The following is a description of a gene set: A molecular function regulator that activates or increases the activity of its target via non-covalent binding that does not result in covalent modification to the target. studied in species Mus musculus Mouse Gene Set: GOMF_MOLECULAR_FUNCTION_ACTIVATOR_ACTIVITY, and this is the list of marker genes: Dnaja1, Jag2, Bmp15, Pde8a, Agt, Gdi2, Wnt10a, Ramacl, Cxcl13, Atp6ap1l, Nppb, Lta, Il27 (interleukin 27), Eda, Acsl1, Tnf, Retn, Psmd14, Krtcap2, Adrm1b, Casp8, Arhgap9, Fnip1, Rheb, Adipoq, Rasa2, Mob1b, Apoa1, Mill2, Ccl17, Guca1b, Ccl21f, Nrg3, Tafa1, Arhgap28, Chn2, Tank, Ins1, Esp3, Rgs4, Il2, Ranbp1, Wnt16, Sema3c, Igfbp2, Pcna (NCBI Gene Id 18538), Elmod3, Il17c, Ghrh, Ereg, Sema4g, Stc2, Flrt3, Plcb3, Plaa, Esp4, Ifna1, Ctsg, Ralgapa1, Psenen, Map3k9, Il1f10, Tbc1d10a, Gpihbp1, Fbn1, Lrrc32, Gdf1, Alkbh1, Prkag2, Tab1, Tor1aip1, Tbc1d30, Pdyn (NCBI Gene Id 18610), Bmp4, Flcn, Gdnf, Fshb, Als2cl, Sema3f, Adap1, Retnla, Mark2, Adcyap1, Csf1, Tbc1d22b, Arap2, Ctsc, Spp1, Noxo1, Tnfsf13b, Sav1, Cflar (NCBI Gene Id 98571), Fasl, Tnfsf9, Il1rn, Mif, Pgf (NCBI Gene Id 18654), Smap2, Lrrc55, Dazap2, Myo9a, Ccnd3, Phactr4, Cbx8, Prok1, Stx4a, Iapp, Clcf1, Trmt112, Prl2c1, Bmp3, Il24, Timm50, Ring1, Cks2, Gm13283, Ccl22, Mtss2, Apln, Ccl4, Pnoc, Ifne, Ppp2r5b, Serinc5, Lama5, Apoa2, Lrg1 (NCBI Gene Id 76905), Ube2n, Prr5, Ltf, Timp2, Arhgdia (NCBI Gene Id 77176), Apobec1, Il15, Sectm1a, Tnfsf12, Mlst8, Reg3a, Blm, Arhgap39, Angpt1, Wnt10b, Sec23a, Nckap1l, Acrbp, Reg1, Bag6, Gprc5d (NCBI Gene Id 93746), Il13, Gcn1, a, Hdgf, Gdf7, Ccl3, Crlf1, Cab39l, Prl7c1, Arhgap15, Jag1, Esp36, Ltb, Thpo, Arl1, Arap1, Gna12, Defb48, Cxcl15, Arhgap17, Map2k2, Rgs16, Garnl3, Fgf12, Ccnb1-ps, Tgfb2, Nrp1, Sgsm2, Atp1b2, Ccl1, Rab3gap2, Mob1a, Prl5a1, Klk1b3, Gal, Fbxw7, Tbc1d1, Copa, Ccnt1, Agfg2, Nxnl1, Dnajc15, Cdk5r1, Prl7a1, Apoe, Arhgap8, Ifna6, Fgf1, Htra1, Flrt2, Il16, Ddost, Plekhg6, Coq9 (coenzyme Q9), Pdcd5-ps, Ndp, Spry2, Uts2b, Rasa4, Rap1gap2, Tg, Pdzd11, Sipa1l2, Angptl3, Pex12, Arhgap19, Il12b, Il36b, Stap1, Rplp1, S100a4, Dpm2, Sema5b, Fgf23, Stxbp5, Pspn, Tbc1d20, C1qtnf9, Ric8a, Colec10, Ccl11, Ltk, Cdnf, Flt3l, Sec23b, Arhgap30, Htr2b, Map2k1, Vegfc, C9orf72, Acap2, Fgf7, Polg2, Prl8a1, Gm13272, Gdf11, Esp31, Mob2, Chml, Stxbp5l, Ncf4, Gfer, Asap3, Tbc1d24, Parp16, Ccnd2 (cyclin D2), Hmga1b, Cks1brt, Gprc5c, Clec11a, Tnfsf11, Alkal2, Tgfb3, Nanos3, Wnt7b, Cks1b, Nsmaf, Tor1aip2 (torsin A interacting protein 2), Osgin1, Git1, Calm2, Pcolce2, Fgf10, Il9, Aph1b, Wdr4, Lrrc52, Pdpk1, Cxcl1, Cxcl9, Artn, Rab3a, Gdf9, Pcolce, Stradb, Nodal, Tbc1d9b, Stard8, Mmrn2, Cd70, Vsir, Ccn2, Ltbp1, Clu (clusterin), Ajuba, Il20 (NCBI Gene Id 58181), Sipa1l1, Prl8a2, Wfdc21, Rab4a, Elmod2, Gm1527, Ghrl, Thbs4, Ambra1, Pglyrp1, Arfgap1, Tnfsf18, Tac4, Vrk3 (vaccinia related kinase 3), Ncf2, Sst, Dock2, Acvr2b, Nlrp1b, Rps27l (NCBI Gene Id 67941), Ifna16, Ucn3, Rabep1, Wnt1, Naa16, Hspa1a, Ccdc88a, Arhgap36, Hscb, Areg, Asap1, Als2, Rln1, Sh3pxd2a, Ccl19, Fgf18, S100a7a, F2rl2, Retnlb, Dusp19, Eef1a1, Calm3, Dcp1b, Hamp2, Rabep2, Wdr48, Arhgef1, Tcl1b4, Car9 (carbonic anhydrase 9), Mt3, Dad1, Cdc20b, Rgs8, Akt1, Rinl, Tbc1d2b, Il22b, Kng2, Il36rn, Angpt2, Gdf6, Tslp, Ralgapa2, Ifna15, Wnt5b, Bmp8b, Prl8a9, Gh, Tff1, Ly6g6e, Pomc, Syde2, Nbn, Fermt2, Fzr1, Rgcc (regulator of cell cycle), B3gat3, Ccl20, Rab6a, Ralbp1, Aimp1, Ahsa1, Sema4b (NCBI Gene Id 20352), Fbn2, Cd274, Arhgap44, Ebi3, Nenf, Insl3, Nppa, Wdr20rt, Hmgb1, Prl, Avp, Pdcd5, Casp8ap2, Klk1b4, Gm44501, Ifna4, Reg3b, 3110082I17Rik, Ntf5, Ppp2r5c, Prkra, Abi1 (NCBI Gene Id 214715), Arl2bp, Gmip, Tbc1d17, Arhgap1, Naa25, Gprc5b, Rasa3, Gdf15, Esp22, Nppc, Alk, Arhgap4, Wnt3a, Guca2b, Sema6a, Parp6, Lep, Gdf3, Tbc1d5, Lars1, Entrep1, Azin2, Defb7 (NCBI Gene Id 246080), Wnt7a, Prl8a8, Fgf16, Rapgef2, Esp16, Pdgfd, Ppp4r3c2, Osm, Ccl19-ps1, Dnajb2, Samd15, Arhgap10, Fgf11, Cyb5b, Ifnl3, Cxcl2, Hdgfl3, Fam3b, Calcb (calcitonin-related polypeptide, beta), Irgm2, Ccl5, Tnfrsf10b, Pttg1, Msmp, Csf2, Inhba, Syde1, Dgkq, Pik3ca, Arhgap29, Topbp1, Dnajb6, Prl3b1, Notch1, Penk, Il17a, Amelx, Arhgef15, Daxx, Rp2, Gas6, Tbc1d9, Taok1, Ercc5, Htr2a, Btc, Cacna1s, Ppp2r5d, C3, Il4, Sema7a, Ccl27a, Atp1b1, Psme2, Bcl10, Ifna7, Inha, Sema3e, Igfbp5, Mdk, Vac14, Rgs17, Fbrs, Ccl12, Cer1, Qrfp, Cklf, Fgf13, Ccnd1, Smdt1, Gnas, Tbc1d16, Git2, C1qtnf4, Nrg4, Itsn1, Pf4, Rack1, Epgn, Dnaja2, Crlf2, Arhgap22, Adap2 (NCBI Gene Id 216991), Pgam5, Tbc1d2, Tiam2, Ecrg4, Ambn, Arhgap21, Fgf20, Ccl26, Rgs6, Insl6, Ifnz, Inhbe, Prl3d2, Tcl1b3, Trp53, Nanos2, Gm13275, Sdhaf4, Depdc1a, Apoc2, Cd86, Nrg1, Prex1, Nkrf, Igf1, Rasal3, Tagap (T cell activation Rho GTPase activating protein), Lgmn, Il6st, Agrn, Nprl2, Sh3pxd2b, Mapk9, Adgrb3, Rangap1, Sema6c, Ccl28, Il21, Ccl9, Elmod1, Ins2, Ctf2, Deptor, Dnttip1, Tcl1b2, Chn1, Defb5, Esp1, Rgs10, Malt1, Il17f, Il18, Ifna9, Eed, Clpx, Ifnl2, Aph1c, Mup1, Hras, Rgs20, Prl3a1, Parp8, Mstn, Arhgef19, Cd40lg, Ifnk, Fam47e, Tgfbr2, Fgf3, Ppard, Rgs11, Fbln1, Mid1ip1 (NCBI Gene Id 68041), Tex24, Strada, Il17d, Fgf6, Ccn3, Csf3, Depdc1b, Ifnab, Ncf1, Ostn, Ophn1, Tafa4, Fam13b, Wrnip1, Gpnmb, Rin1, Nlrp1a (NLR family, pyrin domain containing 1A), Syngap1, Jun, Parp1, Srgap1, Dnajc24, Tbc1d14, Tcl1, Adm2, Dmwd, Ccnt2, Bmp1, Bcr, Tmeff1, Gdf2, Metrn, Arhgap25, Gm2a, Map3k13, Gfral, Nectin2, Asap2, Il22, Brpf1, Oxt, Gip, Bdnf, Saa3, Il23a, Afap1l2, Retnlg, Pdgfa, Psmc3ip (NCBI Gene Id 97716), Il33, Rgs9, Alox5ap, Apoa5, Map2k7, Nsd3, Coq8a, Fndc5, Fgf2, Ctsh, Angpt4, Reg3g, Nherf1, Elk1, Inhbb, Llgl2, Defb46, Crhr2, Prss22, Dele1, Rgs12, Ppp4r3c1, App, Pycard, Raf1, Grm5, Arhgap45, Wnt2 (wingless-type MMTV integration site family, member 2), Dab2ip, Ccn5, Tbc1d13, Vcp, Wnt2b, Gmfg, Suz12, Tefm, Prl3c1, Erbb3, Metrnl, Rabgap1l, Cxcl17, Cdk5r2, Arhgap24, Arhgef10l, Gdf10, Atp1b3, Vip, Il7, Ralgapb, Spx, Arhgap27, Prl2a1 (prolactin family 2, subfamily a, member 1), Mgst2, Bad (NCBI Gene Id 12015), Il1a, Esp38, Ppp4r3b, Ccl8, Bcas3, Slc39a10, Cxcl14, Rgs7, Ddx3x, Prl7d1, Dnmt3l, Ogn, Arhgap32, Tbc1d10c, Wnt5a, Ptn, Rap1gap, Apoh, Nprl3, Sema3d, Tnfsf8, Pth, Agap1, Fgf14, Dock5, Ccl19-ps6, Nkx3-1, Arap3, Il1b, Tbc1d8, Pcgf2 (polycomb group ring finger 2), Aim2, Chm, Cab39 (NCBI Gene Id 98246), Btrc (NCBI Gene Id 12234), Mia, Grtp1, 1700006A11Rik, Lrcol1, Racgap1, Il5, Esp8, Wdr20, Map3k20, Il34, Nlrc4 (NLR family, CARD domain containing 4), Lhb, Mill1, Tafa3, Hif1a, Rgs18 (NCBI Gene Id 64214), Amh, Azin1, Izumo1, Myo9b, Ccl21b, Cmtm2b, Jmjd6, Bmi1, Fn1, Iqgap1, Stk3, Igtp, Cxcl10, Gtf2h4, Eif5, Gtf2f1, Gphb5, Ccl7, Bmp8a, Edn2, Calm1, Arfgap2, Gnaq, Sgsm3, Agap2, Cga, Il19, Rictor, Plcb1, Cav1, Abhd5, Cntf, Arhgap26, Grn, Cd80, Bglap, Timp1, Cmtm5, Erfe, Tiprl (TIP41, TOR signalling pathway regulator-like (S. cerevisiae)), Ppp4r3a, Apoa4, Aurka, Grem1, Gnb5, Ifna11, Iqgap3, Guca2a (NCBI Gene Id 14915), Wnt3, Defb3, Ifna2, Grem2, Bicra, Uts2, Srgap2, Btk, Efemp1 (epidermal growth factor-containing fibulin-like extracellular matrix protein 1), Tnfsf4, Rln3, Rin3, Npff, Park7, Pmch, Ulbp1, Elp2, Tnfsf14, Vegfb, Sema3a, Pik3r1, Evi5, Adrm1, Rabgap1, Manf, Ppy, Cd33, Gpi1, Tbc1d21, Hmga1, Tbc1d8b, Ltc4s, Gcg, Ntf3, Pdgfc, Tbc1d25, Ccl21a, Cripto, Rgs14 (NCBI Gene Id 51791, regulator of G-protein signaling 14), Gapvd1, Il36g (interleukin 36G), Tbc1d10b, Ifna12, Slc27a1, Ercc6, Slx4, Vgf, Stk11, Igf2, Rgs1, Epha2, Ptpa, Cx3cl1, Tbc1d22a, Gipc1, Sh3bp1, Arhgap12, Pthlh, Prl2b1, Gdi1, Incenp, Defb14 (defensin beta 14), Ect2, Tsc2, Tnfsf15, Casp3, Cdc20, Nek9, Wnt8a, Fgf15, Gm13271 (NCBI Gene Id 435791), Cartpt, Prkcd, Crh, Insl5, Atg13, Hamp, Gnrh1 (NCBI Gene Id 239161), Defb47, Igfbp3, Llgl1, Sectm1b, Pdgfra, Agfg1, Dnajb1, Trem2, Ddit3, Slit2, Sema4c (NCBI Gene Id 98332), Depdc5, Egf, Rasa1, Ankrd27, Angptl8, Cdc42ep2, Pdgfb, Abr, Gm6040, Nupr1 (nuclear protein transcription regulator 1), Pim1, Epo, Gm13277, Cxcl5, Tnfsf10, Svbp, Hsp90ab1, Spdya, Sema4a, Sipa1l3, Map3k12, Lgals1, Ifng, Lamtor3, Dand5, Reln, Osgin2, Iqgap2, Tafa2 (TAFA chemokine like family member 2), Il11 (NCBI Gene Id 16156), Nanos1, Tbc1d4, Sema6d, Il3, Esp23, Ncstn, Lefty2, Sema4d, Rgs2, Gpha2, Nampt, Cxcl16, Sec14l2, Psme4, Arhgap42 (Rho GTPase activating protein 42), Apela, Arhgap40 (Rho GTPase activating protein 40), Defb8, Dpm3, Gast (NCBI Gene Id 14459), Mtcp1, Ifna13, Fam3c, Dnajb4, Bmp10, Ppp2r5a, Ccl19-ps3, Caprin1, Mob3c, Arhgef12, Gmfb, Usp6nl, Scg2, Defb4, Atp2a3, Sema4f, Galp, Sgsm1, Sema6b, Il25, Mnat1 (menage a trois 1), Ccl21d, Prl6a1, Ccnq, Nectin4, Nf1, F2, Vegfa, Psme1 (NCBI Gene Id 19186), Dlc1, Clps, Wnt9b, Arhgap33, Zfp106, Ccl25, Ube2l3, Fgf17, Rab3gap1, Gpr158, Acap3, 6030468B19Rik, Agap3, Lrrk2, Ppp2r5e, Src, Fgf9, Sirt1, Rbck1, Guca1a, Cmtm3, Ramac, Ctnnb1, Stim1, Kitl, Prl2c3, Fyn, Tcl1b5, Serinc1, Fgf4, Ccnb1, Nrtn, Ocrl, Il17b, Ppbp, Bmp2, Akt2, Tbc1d7, Stc1, Sct, Mapk8ip2, Ctf1, Evi5l, Sfrp2, Il31, Bmp5, Wnt11 (NCBI Gene Id 22411), Prl8a6, Tifab, Itga1, Wnk1, Dock3, Cck, Prl7a2, Itpripl1, Ngf, Fgf5, Stard13, Hmgb2, Etaa1, Lrrc26, Esp34, Cmtm2a, Srgap3, Cavin4, Lck, Gkn1, Dll1, Nrros, Cwf19l1, Adm, Ttr, Ccl2, Rptor, Nek7, Prl7b1, Cd320, Arhgdib, Wnt9a, Rasgrp3, Cxcl11, Apaf1, Ccn6, Pin1rt1, Arhgap11a, Agrp, Thy1, Lrrc38, Cxcl12, Fgf21, Fgf22 (NCBI Gene Id 67112), Wnt4 (NCBI Gene Id 22417), Nlrp3, Cxcl3, Esp24, Nmb, Cdkn1b, Egfr, Eng, Sema3b, Esp6, Mup20, Apoc2l, Prl4a1, Ranbp2, Efna5, Cdk5, Clpsl2, Ifna5, Tafa5, Dock4, Grp, Dbf4, Gm13276, Arhgap23, Xcl1, Atp6ap1, Dnajc19, Hspe1-rs1, Arhgap5, Tbck, Sipa1, Mmp25, Mob3b, Cmtm8, Mbtps2, Rad50, Pyy, Ccl19-ps4, Ssbp1, Lrpap1, Bmp6, Npvf, Il6, Itgb6, Cd24a, Ncs1, Nrg2 (neuregulin 2), Hcrt, Nbl1, Smcr8, Hgf (NCBI Gene Id 15234), Arhgap20, Tshb, Trh, Arf1, Gprc5a, Ccnk, Lefty1, Inhbc, Hspd1, Irgm1, Tbc1d15, Ucn2, Hbegf, Mob3a, Aph1a, Enho, Strit1, Acap1, Wnt8b, Lif, Npy, Il10, Edn1, Met, Gpr15lg, Lgals9, Gdf5, Prl2c5, Nts, Rplp1rt, Jak2, Pin1, Kng1 (kininogen 1), Ccl24, Prkce, Bmp7, Prl3d1, Pten, Ccl21e, Prl3d3, Tgfa (NCBI Gene Id 21802), Ptk2, Pak2, Fam20a, Dnajc10, Il12a, Alkal1, Rock2, Arf4, C1qtnf12, Arhgap18, Skp1, Arhgap6 (NCBI Gene Id 270682), Scgb3a1, D1Pas1, Arhgap35, Atp4b, Tnfsf13, Tcl1b1, Prex2, Tbcd, Cdkn1a, Grpel1, Wnt6, Rin2, Ifnb1, Cort (NCBI Gene Id 12854), Ccl6, Dll4, Il36a, Prlh, Tac1 (tachykinin 1), Esp18, Cox17, Sema5a, Noxa1, Cmtm7, Tom1l1, Ucn, Vegfd (NCBI Gene Id 14205), Psme3, Prl2c2, Defb33, Ahsa2, Esp15, Ccl19-ps5, Sema3g, Arrb1, Apob, Arhgap31, Lgals3, Arfgap3, Rgs3, Cited2, Tgfb1, Ifna14, Arhgdig, Rasal1, Dpp4, P2rx7, Defb6, Rgs5, Fgf8, Slurp1, Bglap2, Edn3, Dcp1a, Naa15, Insr, Smap1, Zp3, Tbc1d12, Epha7 (Eph receptor A7)